The following is a description of a gene set: Reactome Pathway: Activation of SMO part of: Hedgehog 'on' state electronically inferred by orthology from the curated human pathway studied in species Mus musculus This event has been computationally inferred from an event that has been demonstrated in another species.<p>The inference is based on the homology mapping from PANTHER. Briefly, reactions for which all involved PhysicalEntities (in input, output and catalyst) have a mapped orthologue/paralogue (for complexes at least 75% of components must have a mapping) are inferred to the other species., and this is the list of marker genes: Cdon, Arrb2, Ihh, Csnk1a1, Shh, Smo, Gas1